Given this list of marker genes IFT43, BBS9, HNRNPK, CCN2, CHSY1, SOX10, CREBBP, TPM3, TENT5A, VAC14, WDR73, CBS, PAPPA2, SOX5, BBS5, ADAMTS10, CFAP418, SLC29A3, TMEM165, PIGA, HLA-DQB1, ATP6V1A, CACNA2D1, SYNGAP1, EFL1, DYRK1A, HSPA9, TERC, USH1C, USP9X, AMMECR1, IFT27, SLC19A1, ZIC2 (Zic family member 2), FGFRL1, PLOD1, RREB1, ZBTB7A, EDARADD, TAF6, SLC38A3, BCAS3, BBS10, GJA1, CDK10, GABRB2, OCRL, PLEC, ELANE, DPYD, CTBP1, RNF13, SH3PXD2B, FLNA, OFD1, FLRT3, CCDC8, INSR, FGF3, TSPEAR, ALPL, CLCN7, KRT6B, KLK4, C1R, CARS1, KCNC2, RNF2, COX4I2, KDM1A, PEX1, SLC12A2, SLC24A4, TAF4, KISS1, ESPN, ABL1, SLC35A2, CCDC28B, KAT6A, AGXT, TERT, DLX4, ARL6, MYO7A, RHOA, MASP1 (MBL associated serine protease 1, NCBI Gene Id 5648), PGAP1, NHP2, FOSL2, COMT, SMARCC2, RUSC2, ATP6V1B2, EYA1, HNRNPH1, GATA1, CDC42BPB, TUBGCP2, SMC1A, RIPK4, KREMEN1, SIX1, SCLT1, RPS23, PERP, KDM5C, RMRP, FLCN, KCNN3, DLX3, CEP152, PACS2, DPP6, ATP6V0A2, LIPH, UPF3B, ABCC9, OCA2, LMX1B, NFIX, TBX4, HS2ST1, DNMT3A, C1S, LAMC2, RECQL, B4GALT7, PLCH1, ITGA7, EDA, SMC3, AMER1, WNT10B, AARS1, FOXH1, ASL, AIRE, SELENON, POLR1B, KMT2A, MSX2, RSPRY1, TPRKB, SMARCD1, DCHS1, DVL3, HOXD13, FBXO28, PIK3CA, SGMS2, DSP, NSUN2, WRAP53, SOX9, PRKACA, IFIH1, DSPP, XYLT2, SMOC2, CACNA1I, TFAP2A, SLC35C1, OBSL1, AAGAB, CTDP1, ARID2, COBLL1, ADAMTS15, MKRN3, FARS2, PACS1, TGFA, DHCR7, PIGG, NDNF, TNFRSF11B, POLR1A, PUF60, IL17RC, CERT1 (NCBI Gene Id 10087), MCTP2, ST14, LOX, BRD4, SLC25A24, IL11RA, GRIA3, PKP1, WDR72, UBE3B, HDAC8, SMARCB1, PIGS, GTF2E2, SMARCA2, PLEKHM1, MEIS2, NUP107, RAB3GAP2, EDN1, LEMD2, KATNB1, GRHL2, SKI, GPC3, FUCA1, SRD5A3, AMELX, DSC3, ALKBH8, CDK13, MARS1, NKX6-2, COX7B, PARN, KRT17, MMP1 (matrix metallopeptidase 1), CLIP2 (NCBI Gene Id 84805), BANF1, TRIM37, GJB6, BCL11B, CYP4F22, LARP7, THOC6, FRAS1, GABRA5, WDR4, PRKAR1A, EDNRA, CLEC7A, SMG8, ACP5, NSDHL, MECP2, SP7, ALX3, KIF1C, RAB3GAP1, FGFR2, VPS51, CILK1, TRPS1, POLR3A, ANOS1, KANSL1, DHODH, ODAPH, HBB, NECAP1, SPART, GTF2I, PDGFRB, CAV1, LTBP3, CEP120, CLTC, KCNQ1OT1, NDUFB11, ZNF141, KIDINS220, POLR2A, SBDS, GORAB, ERCC5, UBA5, KCTD1, NARS1, SON, GDF5, NRAS, ZDHHC9, CHST3, GTF2IRD2, PTPRF, AEBP1, BPTF, TRIO, KRT81, TRMT10A, STX1A, PDGFRA, CHRNG, PCGF2, WNK3, PDE4D, BAP1, SCN1A, HLA-DQA1, TARS1, TSC2, GNRHR, HMGA2, FAM83H, CDON, DKC1, PYROXD1, PAX9, TRAF6, FGF10 (NCBI Gene Id 2255), SZT2, AGA, BBIP1, KAT6B (NCBI Gene Id 23522), ADAT3 (NCBI Gene Id 113179), CUL4B, TCF4, ALX4, GNB2, GLB1, SNRPB, CYP27A1, TPM2, CNOT1, MED12, MBD5, TBCE, ARID1B, ASXL3 (ASXL transcriptional regulator 3), NPAP1, TBC1D24, SEMA3A, FREM2, FGF12, KRT83, TRAK1, CRLF1, APCDD1, CDH11, EHMT1, SEC24C, WNT10A, HMGB3, ADAMTSL1, CACNA1A, COL17A1, KCNA2, TBL2, SOS1, KCNE5, GJA5, LTBP2, PIK3R1, SHOC2, DDR2, SOX18 (NCBI Gene Id 54345), SMAD2, GRB10, AKT1, EDAR, MADD, PEX6, BAZ1B, VARS1, NONO, HOXC13, RNF113A, WDR26, FGF23, USB1, IFNG, SCN8A, SUFU, POLD3, SP6, KIF7, ITGB2, PTH1R, MTM1, ELN, XYLT1, SCN3A, EIF4A3, PRDM5, MKS1, CHD7, LYST, GALNS, ZSWIM6, FKBP10, SIN3B, WDR11, SCUBE3, EMC10, TGM1, CHD3, CTC1, CCDC141, NECTIN4, ABCA5, MYSM1, SNORD115-1, TTC8 (tetratricopeptide repeat domain 8), P4HB, ACTA1, KISS1R, FGFR3, GREM2, RAD21, CRIPTO (NCBI Gene Id 6997), RIC1, AFF3, LIMK1, BMP1, PQBP1, HUWE1, NPHP1, DCC, POLR1C, TMEM270, TTI2, ZMYM2, ERCC8, TCOF1, C2CD3, MGAT2, ARSK, BRF1, AHDC1, GJB2, LRP5, MYH3, ARHGAP29, EXT1, UBR1, WDR35, NECTIN1, FZR1, CAMK2B (NCBI Gene Id 816), AHCY, GFI1, KCNMA1, ATP1A2, TRAIP, HRAS, AMTN, CELF2, DNAJC21, NDST1, WBP4, METTL27, NMNAT1, LRP6, CCDC47, MAN2B1, POLR3B, CA2, RTEL1, VPS13B, FEZF1, FIG4, B3GLCT, SCNM1 (sodium channel modifier 1), PRR12, RPL10, SMARCE1, UROD (NCBI Gene Id 7389), BBS12, NEPRO, HERC2, LIPN, KCNJ2, TINF2, DOCK3, SEC23A, COL3A1, COL7A1, CPLX1, FGF8, YY1, COL5A2, CACNA1C, PIGL, SYNJ1, NHLH2, NAA80, CTNND1, RIGI, APC, PIGK, DEAF1, TBL1XR1, NSD1, PAX1, GLI2, IFT52, SCARF2, DDX59, DOCK7, DMP1, IL17RD, PRMT7, PYCR1, STIL (STIL centriolar assembly protein, NCBI Gene Id 6491), PUM1, ASPRV1, C12orf57, RAI1, DISP1, FGF17, FN1, POLD1, FAM20A, MAPK1, PDZD7, FAT4, FREM1, FKBP6, FOXG1, ITPR1, GNRH1 (gonadotropin releasing hormone 1), COL1A2, MYOD1, ATP6V1E1, MCOLN1, TRPM4, HCCS (NCBI Gene Id 4307), KDF1, RDH11, CEP295, NHS, XPA, B3GAT3, ANAPC1, NALCN (sodium leak channel, non-selective), STAG2, EFEMP1, IRF5, RFC2, KCNB1, UBE3C, UFD1, MYMX, CEP19, DCAF17, GRIP1, TRIP11, PLOD3, SPEN, SERPINF1 (serpin family F member 1), ADAMTS3, TNFRSF11A, CSTB, GRHL3, ORC1, KIFBP, IKBKG, FGD1, IGF2, CLP1, SETD1A, MED13L, SNRPN, TWIST1, STX16, DPH5, DNM1, KRT86, ALOX12B, NPM1, B3GALT6, MAP2K1, TSC1, GFPT1, COL9A2, XPC, ANKH, BBS2, EP300, PPP1R13L, SMS, ARVCF, PPIB, BUD23, DHDDS, KCNJ5, SLC1A2, CENPE, AP3B1, TRIM32, SPARC, AXIN2, CEP85L, DNAJC30, REV3L, PLCB4, LGI4, GTF2H5, SUMO1 (small ubiquitin like modifier 1), HS6ST1, ALOXE3, HLA-DRB1, IFT74, SHH, NXN, EVC, PITX2, ADGRV1, SIN3A, KRT5, SETBP1, ZNF341, SCN4A, MAGEL2, RLIM, MLXIPL (MLX interacting protein like), TONSL, NKX2-1, CTSK, SMCHD1, CNNM4, SRP19, ZFX, H4C5 (H4 clustered histone 5), SMARCAL1, DSG4, PCNT, SOST, GP1BB, NAA20, BCOR, SATB2, GUSB, JMJD1C, NSMF, MKKS (NCBI Gene Id 8195), PSMD12, PWRN1, FZD2, SDCCAG8, TCF12, WDR19, FAM111A (NCBI Gene Id 63901), WHRN, ATR, CNOT2, BRCA1, PAK2, ANTXR1, SMARCD2, IL6ST, KMT2D, KMT2C, COG6, DNA2, KRT14, POP1, LZTFL1, NEK1, TEKT3 (tektin 3), FOXC1, TMCO1, NOTCH2, PRIM1, PRKACB, CKAP2L, EIF4H, ACP4, CLDN19, ATRIP, TGIF1, ANKRD11, CEP290, LONP1, DPF2, PROKR2, CXCR4, BMP2, SNORD116-1, MEGF8, FBN1, RAD51, CDH3, TBX1, HECTD4, SSR4, LPAR6, SOX11, SLF2, TRAF3IP2, CNTNAP2 (NCBI Gene Id 26047), LMBRD2 (LMBR1 domain containing 2), DVL1, P3H1, CRTAP (NCBI Gene Id 253263), ADNP, SOX4 (SRY-box transcription factor 4), DDB2, CYFIP2, GHR, ITGB4, CAMTA1, CDH23, DRG1, BMP4 (NCBI Gene Id 652), LAMA3, PTEN, PTDSS1, UBE3A, ALMS1, EXOSC5, LIFR, PNPLA6, IQSEC2, SMOC1, AGO2, RPS6KA3, GLI1, HCN1, RUNX2, RAP1B, ATRX, HSPG2, TSPAN7, TNFSF11, MAF, TGFB1, FGFR1, PTHLH, HK1, KCNH1, TAC3, COL11A1, SMC5, FLII, LMNA, IGF1, CTSC, DPH1, WWOX (NCBI Gene Id 9621), RNU4-2, APC2, ZMPSTE24, CCR6, IRF6, ZNF469, LMNB1, PLK4, BRAF, PLXNA1, MSX1 (msh homeobox 1), TWIST2, NODAL, PRKD1 (NCBI Gene Id 5587), OSGEP, EDA2R, NOP10, PLG, ADAMTS2, PUS7 (NCBI Gene Id 54517), DLL1, MAP3K7, USH2A, CLPB, GBA1, ENPP1, TYMS, HDAC4, CUL7, IFT172, DUSP6, SETD5, TBX3, IRX5, WDPCP, TP53RK, PIGT, NAA10, CHD6, PIK3C2A, CDK5RAP2, EVC2, LAMB3, ENAM, PLXND1, MYL2, GNAS, UROS, MMP2, DYNC2LI1, SPRY4, GPR68, GALNT3, MMP13, LETM1, ZNF526, ITGA6, NSD2, RPL21, KCNK9, MAPRE2, RELT, KIAA0753, SATB1, ASCC3 (activating signal cointegrator 1 complex subunit 3), IDUA, TCIRG1, SASH1, LIG4, TACR3, LEMD3, DSE, POLR3GL, AMBN, ACSL4, IDS, KRT71, SLC10A7, MESD (mesoderm development LRP chaperone), DLG1, CLDN1, FAM20C, KRAS, TBCD, ANTXR2, ERCC2, EIF2S3, DALRD3, CYP27B1, CDK19, ROGDI, NIPBL, EPS8L3 (EPS8 signaling adaptor L3), DPM2, SET, SH3BP2, KDM5A, USH1G, PPP1CB (protein phosphatase 1 catalytic subunit beta), ITGB6, SCAPER, KDM6A, ORAI1, ABCA12, TBC1D2B, POU4F1, ALDH3A2, PCDH15, MAPK8IP3, PURA, JUP, CTCF (CCCTC-binding factor), RECQL4, CLDN16, ARSB, CCDC134, COL2A1, PCYT1A, ROR2, KIF15, TFAP2B, IFT140, TMEM38B, KRT74, SNX10, ERCC6, PTCH1, VDR, COL1A1, NUP85, EEF1A2, DHX37, SNX14, RBBP8, HIRA, HACD1, ACTL6B, PPP2R3C, SEC24D, SLC37A4, ERCC1, NF1, RIN2, DPH2, MBTPS2, GLI3, ERCC4, POLR1D, CIB2, SRCAP, CDC42, SNAP29, SFRP4, NUS1 (NUS1 dehydrodolichyl diphosphate synthase subunit), PPP3CA, PTPN11, VPS37D, SUOX, NPHS1, PTCH2, GABRA2, RSPO1, GON7, MPLKIP, SEMA3E, RHOBTB2, TRPV3, AIP, CDSN, SOBP, NELFA, STAG1, OTUD5, NIPAL4, SIX3, HEPHL1, GNAI3, SULT2B1, MMP20, AP3B2, BBS1, IL17F, PROK2, IFT122, NTRK2, HIVEP2, CDH1, GPR101, CCBE1, ZEB2, TP63 (tumor protein p63), GJA8, CAT, RNU12, NFKBIA, CUX1, YRDC, MTX2, COL5A1, KDM6B, YWHAG, NEDD4L, HESX1, CHRNE, ARHGEF38, SMARCA4, WNT5A, PWAR1, IL1RAPL1, AIMP2, IFITM5, NCF1, BBS7, THRA, DIAPH1, GABRG2, NUP133, STIM1, GRIN2D, POLR3K, INTU, EFNB1, RAB23, LBR, ASPH, RBM28, KRT6A, PIGF, XRCC4, SLC39A13, CNKSR2, GNAQ, ACVR1, HMBS, SERPINH1, GABBR2, IFT57, CBFB, PORCN, BLM (BLM RecQ like helicase), PARS2, PGM2L1, MED27, SHANK3, PHEX, BBS4, SPECC1L, CYP2R1, PPP1R15B, SMAD3, POC1A, NGF, LRP4, ARID1A, GATAD2B, ELMO2, CACNA1B, GPC4, KRT85, MID1, MIA3, FLNB, H19, NOTCH3, SLC13A5, ACOX1, TTC7A, CREB3L1, TANC2, SDR9C7, IL17RA, ATP1A3, KRT16, FERMT1, TTI1 (TELO2 interacting protein 1), GTF2IRD1, TECPR2, GAS1, ERCC3 (ERCC excision repair 3, TFIIH core complex helicase subunit), PEPD, NTRK1, MAP3K20, ACD, POF1B, TOMM7, STAT3, LAGE3, here is a description of the gene set: Human Gene Set: HP_ABNORMALITY_OF_THE_DENTITION Any abnormality of the teeth. species: Homo sapiens Abnormality of the dentition